The following is a description of a gene set: species: Homo sapiens A complex containing Cryptochrome proteins CRY1, CRY2, Period proteins PER1, PER2, PER3, and kinases CSNK1D and/or CSNK1E binds a heterodimer containing phosphorylated CLOCK and phosphorylated, acetylated BMAL1 bound to E-boxes in the promoters of target genes (inferred from mouse homologs in Griffin et al. 1999, Langmesser et al. 2008, Ye et al. 2011, Ye et al. 2014, Aryal et al. 2017, Cao et al. 2021). This effectively delivers the kinases CSNK1D and/or CSNK1E to the proximity of CLOCK, resulting in further phosphorylation of CLOCK (inferred from mouse homologs in Cao et al. 2021). NPAS2, which acts redundantly with CLOCK, may be similarly phosphorylated. The phosphorylation of CLOCK causes the dissociation of the BMAL1:CLOCK heterodimer from DNA (inferred from mouse homologs in Ye et al. 2014, Chiou et al. 2016, Cao et al. 2021), terminating the diurnal activation of gene expression by BMAL1:CLOCK. part of: Circadian clock Reactome Pathway: The CRY:PER:kinase complex represses transactivation by the BMAL:CLOCK (ARNTL:CLOCK) complex, and this is the list of marker genes: NPAS2, PER3, PER1, CSNK1D, KMT2A, CREBBP, RORA, BMAL1 (NCBI Gene Id 406), CLOCK, CRY2, CRY1, PER2, CSNK1E, NR1D1